Given this list of marker genes MRPL13, SNX12, LMNA, CARF, DMXL1, PHF10, KIF27, SLC22A25, CHIA, VPS54, MOBP, PPP3R2, OR12D1 (NCBI Gene Id 26530), ASAH2, ALDH1A2, MAB21L1, ERCC5, CANX, VSTM2A, CIAPIN1, OR4C12, CYP2R1, POU2F1, RBL1, STX19, SMYD4, MLH1, HLCS, PRB1, OR10D4P, PSD3, GRIP1, OR4F5, PES1, LIX1, EPB42, REEP5, ECHDC1, DYNC2LI1, MBLAC1, RSPO3, ARTN, SERPINB10, PLPP6, DESI2, OR5M9, HSPB3, MFF, PITX2, PHKB, KAT2B, GLRA3, TAS2R14, DPY19L3, TNFRSF1B, RBP4, FZD8, USP54 (ubiquitin specific peptidase 54), ULK1, CXXC4, ADAM19, PCDH11X, MTHFD1 (NCBI Gene Id 4522), OR8K3, OR4F15, CES1, SACM1L, SERPINE2, VN1R4, MMAA, CDH8, HAS2, RUNX1T1, RXRG, ARHGAP6, SPATA6L, NFAT5, OR5P2, SNAP25, OR6B2, ARMC3, ABCA1, OR4L1, OR4D10, SEM1, GUCD1, PRRX1, ADAM10, ADAM20, OR4K15, LY75, LRRN1, RNF185, MARCHF8 (NCBI Gene Id 220972), IDH3B, RHOBTB3, OR5AS1, OR4C15, COMMD3, SPECC1, PPP3CB, PKN2, VPS36, NEDD4 (NCBI Gene Id 4734), DDX60, OR4K5, POU1F1 (POU class 1 homeobox 1), TRAP1, CDKN2A, OR52P1, OR8G1, SERPINB3, PRG4, TRIP12, PPME1, MMD, H4C6, STAP1, SLC5A7, RFX7, QSOX1, CALU, DUS2, ZNF780A, VN1R17P, POU3F3, C1orf87, RSRC1, CFTR, UGP2, XPO6, TMPRSS11B, ARX (NCBI Gene Id 619216), POLQ, OR5H2, KRTAP19-1, GCN1, JKAMP, ACMSD, KCNJ3, FBXL14, NIPBL, FOXJ2 (forkhead box J2), CCKAR, MAEA, MAPT, TSPAN8, LRIG2, OR6C2, ANK3, OR10G9, INSM1, GNG12, TMED11P, UGT2A3, GTF2A2, R3HCC1L, RLN2, ADAMTS18, GABRB1, AFF4, SHROOM3, C6orf58, DNAJB4, PRAG1, PLCB4, SEPTIN7, CTF1, MITF, PSEN1, RELL1, FBXL21P, ALDH1A1, CYP2C8, PTGS2, STXBP5L, RIC3, RGS9, VN1R5, UBR3, OR1N2, FBXL4, GAB3, FAT1, CHST4, RAN (RAN, member RAS oncogene family), OR7G2, CDC5L, BAIAP2L1, SETDB2 (SET domain bifurcated histone lysine methyltransferase 2), C1orf43, APLF, CFAP53, SERPINB9, XIRP2, here is a description of the gene set: Murine embryonic stem (ES) cells are defined by continuous self-renewal and pluripotency. A diverse repertoire of protein isoforms arising from alternative splicing is expressed in ES cells without defined biological roles. Sall4, a transcription factor essential for pluripotency, exists as two isoforms (Sall4a and Sall4b). Both isoforms can form homodimers and a heterodimer with each other, and each can interact with Nanog. By genomewide location analysis, we determined that Sall4a and Sall4b have overlapping, but not identical binding sites within the ES cell genome. In addition, Sall4b, but not Sall4a, binds preferentially to highly expressed loci in ES cells. Sall4a and Sall4b binding sites are distinguished by both epigenetic marks at target loci and their clustering with binding sites of other pluripotency factors. When ES cells expressing a single isoform of Sall4 are generated, Sall4b alone could maintain the pluripotent state, although it could not completely suppress all differentiation markers. Sall4a and Sall4b collaborate in maintenance of the pluripotent state but play distinct roles. Our work is novel in establishing such isoform-specific differences in ES cells. from publication Rao S, Zhen S, Roumiantsev S, McDonald LT, Yuan GC, Orkin SH (PMID 20837710) Loci bound exclusively by SALL4 isoform a in ES cells (embryonic stem). species: Mus musculus Human Gene Set: RAO_BOUND_BY_SALL4_ISOFORM_A